Given this list of marker genes AXIN1, UNC13B, HVCN1, PARP14, TREM1, SDC2, STAT1, CCL18, CD19, POU2F2, CD27 (CD27 molecule), CD86, THBS1, TTLL2, HLA-DMB, ABTB1, IL2RB, CXCL9, P2RY10, HLA-DMA, SPIB, LIMD2, BST2 (bone marrow stromal cell antigen 2), CSF3 (NCBI Gene Id 170794), POLR3B, CNRIP1, KCNQ5, IFT70A, UTY, ISG15, CD3D, ZNF436, MST1L, CD5, ADGRE2, TNFSF10, KLRK1, IGLJ3, GNLY, ADAM19, BANK1, IGHG3, IFI35, DEFA1, AQP9, BLNK, ATP2A3, CYP1B1, CD79A, CD2, FAM53B, APOL3, TCL1A, HLA-C, IFI44, HLA-DQA1, MS4A1, SAMSN1, UNC79, FCRLA, GBP2, HBA2, IFI44L, HELZ2, PPP1R16B, SERPINA5, CEBPD, FCRL2, LPAR6, FADS1, CD14, CD79B, MECP2, IFITM3, IL7R (interleukin 7 receptor), CCL7, TNFRSF25, CARD16, IFITM1, GSTM2, CD74, OAS1, TXLNGY, UBE2L6, SLC22A23, CACNG4, UCP1, RUBCNL, IGKC, IFI27, CD37, IFIT1, UNKL, RSAD2, NEK11, HLA-DPA1, RRP15, LGALS3BP, CTSL, FPR1, GBP1, STK31, KIAA0753, MX1, UNC5D, FOXP1, HLA-DPB1, TAP1, LGMN, PELI1, HLA-DRA, CCDC186, RNF31, IL3RA, IGHM, PNMA8A, KCTD12, OAS3, TPTE2, SELL, HLA-A, CAMK4, IGLL1, MAL, HLA-DQB1, TNFAIP6, here is a description of the gene set: Immune response and Ag processing and presentation. species: Homo sapiens Human Gene Set: MODULE_345